Given this list of marker genes VWF, CANT1, PLIN4, GLE1, DHDDS, CDON, PMP22, TNFRSF11B, RNASEH2B, MT-CYB, MT-ND6 (NCBI Gene Id 4541), NEFH, COL6A1, EIF2S3, ATL1, SHH, NUP107, FKRP, RTEL1, SLC52A2, SURF1, DPM1, SLC25A26, MT-ND5, DEGS1, PEX2, SPAST, MT-CO2, GJB6, EYA1, FIG4, ADD3, TMEM126A, MT-TQ, SLC2A1, MT-TC, MT-TK, PITX2, FBXO38, QDPR, GFPT1, TPM3, PDHX, HARS1, NAA10, MT-TW, DARS2, MFN2, GABRB2, KRT86, MT-TS2, PRPS1, F2, TH, MT-TV, SCN1A, MT-TL1, SETX, MT-CO3, CHRNE, MPC1, LAMA1, PRDM8, DLX5, GLI2, HDAC8, NIPA1, SAMD9L, GATA1, MT-ND1, GLI3, MT-CO1, PIGN, FGFR2, KIF11, MT-TF, SLC25A46, SLC5A2, TWIST1, KCNA1, here is a description of the gene set: Phenotypic variability studied in species Homo sapiens Human Gene Set: HP_PHENOTYPIC_VARIABILITY A variability of phenotypic features.